Given this list of marker genes Kat2a, Mapt, Armc1, Dnm1l, Synj2bp, Lrrk2, Bhlha15, Ogt, Mfn1, Opa1 (OPA1, mitochondrial dynamin like GTPase), Mfn2 (NCBI Gene Id 170731), Cluh, S2bpcox16, here is a description of the gene set: Any process that establishes the spatial arrangement of mitochondria within the cell. Mouse Gene Set: GOBP_INTRACELLULAR_DISTRIBUTION_OF_MITOCHONDRIA studied in species Mus musculus